The following is a description of a gene set: studied in species Homo sapiens Human Gene Set: MIR4735_5P Genes predicted to be targets of miRBase v22 microRNA hsa-miR-4735-5p in miRDB v6.0 with MirTarget v4 prediction scores > 80 (high confidence targets). from publication Chen Y, Wang X (PMID 31504780), and this is the list of marker genes: PLEKHA2, RBL2, ANKIB1, TMEFF2, SNAPC1, MAGEB3, IGSF1, VKORC1L1, NR2C1, ARHGEF33, PUM2, DPP10, ZDHHC17, SKAP2, TP53BP2, RABEP1, OMD, SCAI, LRRN1, COMMD6, BRWD1, RCBTB1, NCOA2, PRR11, PCDH17, PECR, EED, PHC3, SLC4A4, SHH, RAB3C, PHF20L1, KLHL7, RAB6A, PKN2, CYSLTR1, UBE4A, STAG2, AHR, CNOT6L, CAPS2, UACA, ANKRD62, CNTD1, IGFBPL1, TMEM98, ASB8, ADGRF2P, GRID2, ZFP14, FCHO2, SLIT2, GOSR1, CELF2, ZXDA, HOOK3, RAB6D, TEAD1, QKI, FIGN, LRATD2, AQP4, PPP4R2, CLCN3, CYRIB, XRN1, C2orf66, ITGA4, RAB7A, A1CF, AGPS, ADD2, EPC2, PDLIM5, NTS, WNK3, SF3B1, EFEMP1, ARHGAP21, HERC1, TMEM59, SETD7 (SET domain containing 7, histone lysine methyltransferase), MAP7, COL4A1 (NCBI Gene Id 1282), ZNF382, SUSD5, FREM1, TBC1D9, STON2, GID4, MDC1, WAPL, HYCC2, CADM2, TRMT5, FUT9, ANKRD13C, VWA3B, NRIP1, EFHB, SOX21, PPDPFL, SPRY2, RASSF8, PCSK2, CCDC148 (NCBI Gene Id 130940), VCPIP1, LAMA4, PAICS, LIN28B, SEC24B, PLCB1, AUTS2, RB1, KCNMA1, TWIST1, B4GALT6, MGARP, PHYKPL, CARTPT (CART prepropeptide), GATC, SGTB, MAP2K4, INO80D, SPOPL, NDUFS2, CNGA1, SKP2, LATS2, SIX2, SLAIN2, FPR3, AAK1, PJA2, TRDN, MYO5B, ZC3H12C, NR4A3, CSRNP3, TSPAN2, SRSF3, LCOR, NAMPT, ADGRL3, TRIM33, ENKUR, YBX1, MBNL3, ASRGL1, APOBEC3G, CCDC28A-AS1, UQCRB, SYNE2, SOHLH2, LIN54, ZNF519, PRSS35, STYX, RFX3, THAP1, MASTL, YIPF6, PTGS2, ELK4, PCDH10, SNX29, GNB4, CAMK4, PAIP1, GABRG2, SRPX, RAB6C, DCAF10, ARL4D, DCP2 (NCBI Gene Id 167227), MEST, BOD1L2, LARP4, CREBL2, FZD3, RC3H1, C15orf48, DNAJB14, GOLGA4, CREB1, CDK6, CPEB2